The following is a description of a gene set: Any process that modulates the frequency, rate or extent of translational termination. species: Homo sapiens Human Gene Set: GOBP_REGULATION_OF_TRANSLATIONAL_TERMINATION, and this is the list of marker genes: ETF1, UPF1, OGFOD1, SHFL, EIF5A, EIF5AL1, JMJD4, EIF5A2, GSPT1